Given this list of marker genes Magt1, Nipal4, Mmgt1, Zdhhc13, Nipa2, Tusc3, Slc41a2, Cnnm2, Tmem94, Slc41a3, Cnnm4, Mrs2, Nipa1, Mmgt2, Nipal2, Trpm6, Nipal3, Trpm7, Slc41a1, Kcnj2, Nipal1, here is a description of the gene set: studied in species Mus musculus Mouse Gene Set: GOBP_MAGNESIUM_ION_TRANSPORT The directed movement of magnesium (Mg) ions into, out of or within a cell, or between cells, by means of some agent such as a transporter or pore.